Given this list of marker genes PLA2G4A, KRT81, TFDP1, ENO4, SYNDIG1L, NDUFA9, TMEM255A, BCKDHB, P4HB (NCBI Gene Id 94756), PLEC, COIL, FGF6, LAG3, FSHB, NIFK, UBQLN3, MCRIP2, GABRA5, NOP16 (NOP16 nucleolar protein), BAD, RPL24, PLXNA1, ZCCHC3, ABCG2, CLDN10, MICALL2, AREG, TBX5, C11orf87, ZNF777, MORN5, BPIFB3, MX2, C9, PIK3R5, KCTD4, ADAR, MMP1 (NCBI Gene Id 4312), SLC25A42, MAN1A2, DOP1A, CPLX2, ITPR1, METAP1D (NCBI Gene Id 254042), CACNA2D2, BHLHE41, NPC2, KDM5D, SNAP91, MNAT1, HAPLN3, STOX1, PRELID2, ITGA4, TRIQK, HADH, FAM216B, POMT2, POLR1B, FOS, KDR, NEFH, ZNF280C, TCEAL1, FAM222A, EPCAM (epithelial cell adhesion molecule), PEPD, KPNA3, GRHL1, MXRA8 (NCBI Gene Id 84308), TADA2A, NKG7, ISL1, GATA2, C4orf51, CDK5R2, CLEC12B, SKP1, B3GAT1, SLC43A3, PRELID3A, CHMP4C, PDHA2, S100A6, PCDHA11, ANLN, SCN3B, MUC15, KLHL9, MARVELD1, SLC6A18, SLC19A1, ABCE1, DFFA, COL10A1, HPD (NCBI Gene Id 3242), IFI44L, IQGAP2, CCR4, BCL6, MEDAG, FNDC3B, NCAPD3, TMEM41A, DSTN (NCBI Gene Id 11034), CNNM3, SLC12A2, VPS13B, DKK3, TUBA1B, PTPN1, RPS6KA6, FCGR1A, WDFY4, C19orf38, MFHAS1, MYH14 (NCBI Gene Id 79784), TRIM46, AKAP3, ENKD1, ACVR1C, PDLIM1, AJAP1, SLC39A11, HAO1, DCLK2, STAC2, TTC28, OAS1, SLC38A5, CAMK2A, HPRT1, TENM4, NTPCR, SH3BP4, EVX2, SSBP4, RARRES1, NEB, ARMH4, CACNB4, RNF150, TBC1D24, CMTR1, TPST2, ZFYVE1, TNN, CFAP43, GRB14, ENTPD1, KMT5A, REC8, ANK3, CLDN19, KCNC2, IFI44, IMPDH2, GSE1, OAS2, KSR1, COL27A1, POU1F1, CLEC1A, PLEKHA6, DHTKD1, CDK8, RCC1 (regulator of chromosome condensation 1), PLPP3, SBF2 (SET binding factor 2), AHNAK, CAPZA3, RNF187, GAD1, PIK3IP1, HS3ST3B1, LRRIQ4, KBTBD12 (NCBI Gene Id 166348), CYP4F2, MAP2, ST14, IQCE, DYNC1I1, CCDC183, SVIL (supervillin), TMEM45B, DPP4, OTUB2, NT5DC3, LHX6, SYT1, AQP4, ARHGAP5, CD1D, SLC25A3, ARID5A, ANKRD7, HSD17B3 (hydroxysteroid 17-beta dehydrogenase 3), GRIN2B, STOM, BSN, here is a description of the gene set: Influenza virus infection-induced gene expression changes of regional B cells are mediated at least in part through type I Interferon: Our objective is to determine whether the influenza virus-infection induced gene expression changes in regional lymph node B cells are facilitated at least in part through type I interferon. Our specific aim is to compare the gene expression profile of highly FACS-purified B cells in the regional lymph nodes of wildtype and IFNR-/- mice prior to and 48h following infection with influenza virus infection and to contrast this expression profile with that of FACS-purified wildtype B cells activated in vitro with IFN-beta +/- anti-CD86 for 12h. from publication Chang WL, Coro ES, Rau FC, Xiao Y, Erle DJ, Baumgarth N (PMID 17237394) studied in species Homo sapiens Human Gene Set: GSE3203_UNTREATED_VS_IFNB_TREATED_LN_BCELL_DN Genes down-regulated in lymph node B lymphocytes: untreated versus interferon beta.